The following is a description of a gene set: Any process that results in a change in state or activity of a cell (in terms of movement, secretion, enzyme production, gene expression, etc.) as a result of a hydrogen peroxide (H2O2) stimulus. Human Gene Set: GOBP_CELLULAR_RESPONSE_TO_HYDROGEN_PEROXIDE studied in species Homo sapiens, and this is the list of marker genes: MAP3K5, LCN2, ZNF277 (zinc finger protein 277), HDAC2, CFL1, MIR103A1, RELA, ANKZF1, KLF4, NPPA, SIRPA, RIPK1, PLEKHA1, MAPK7, MIR107, PPEF2, CBX8, KDM6B, PRKAA1, NFE2L2, MDM2, TRPA1, SMPD3, RPS3, PCGF2, AIFM1, ZNF580, KLF2, TRPM2 (NCBI Gene Id 7226), ERN1, ECT2, PPIF, SETX, TNFAIP3, CDKN2A, MAP1LC3A, RIPK3, EDN1, CYP1B1, TOP2B, EZH2, TRPC6, FABP1, PARK7, GATA5, PDGFD, PCNA, BNIP3, FXN (NCBI Gene Id 2395), IL18BP, RHOB, CAT, HDAC6, FYN, IL6, OSER1, HSF1, PPP5C, AQP1, SRC, CDK1, BECN1, ABL1, IL18RAP, SIRT1, TXN, PRKCD, SPHK1, MAPK13, NET1, MYB